Given this list of marker genes Psma1, Frat2, Psma4, Ppp2r5b, Psmc5, Psma3, Axin1, Ctnnb1, Rps27a, Psmd7, Psma2, Tcf7, Psmc1, Psmc6, Psmd6, Psma7, Cul1, Amer1, Psmb4, Psmc3, Psmb6, Psmc2, Psma5, Tcf7l1, Ppp2r1b, Psmb7, Ubb, Psmd12, Ppp2r5d, Psmc4, Frat1, Psma6, Csnk1a1, Psmb5, Tcf7l2, Ppp2r5a, Psmd1, Psmd13, here is a description of the gene set: part of: Signaling by WNT Reactome Pathway: Degradation of beta-catenin by the destruction complex This event has been computationally inferred from an event that has been demonstrated in another species.<p>The inference is based on the homology mapping from PANTHER. Briefly, reactions for which all involved PhysicalEntities (in input, output and catalyst) have a mapped orthologue/paralogue (for complexes at least 75% of components must have a mapping) are inferred to the other species. studied in species Mus musculus electronically inferred by orthology from the curated human pathway